The following is a description of a gene set: Mouse Gene Set: GOMF_CHROMATIN_PROTEIN_ADAPTOR_ACTIVITY studied in species Mus musculus An adaptor activity that brings together a protein and a region of the chromatin, such as a nucleosome, to establish or maintain the chromatin localization of the protein, or the complex to which it belongs., and this is the list of marker genes: Stk38, Topbp1 (topoisomerase (DNA) II binding protein 1), Mdc1, Spin1, Msl3 (MSL complex subunit 3), Lbr, Ttll12, Zzz3, Cbx5, Zzef1, Thap7, Rhno1, Brd1, Dpf2, Uimc1, Rpa1, Mecp2, H2ax, Pih1d1, Chd5, Htatsf1, Glyr1, Jarid2, Pwp1, Taf1, Baz2a, Cbx7, Taf7, Rad17, Yeats2, Kdm4c, Mphosph8, Tonsl, Nbn, Brd7, Zcwpw1 (zinc finger, CW type with PWWP domain 1), Kdm4a, Usp15, Epc1, Cbx2, Hdgfl2, Phf14, Ncoa6, Fgf2, Ing2, Trp53bp1, Dnajc2, Ccdc38, Brdt, Phf13, Rnf169, Chd1l